Given this list of marker genes JMJD1C, TMEM18, NDRG2, RHBDF1, ASIC1, IDE, FLNB, PLEKHM3, GCSAM, SLC12A2, CD68, NEIL1, DRAM2, BID, MALAT1, PLBD1, PLA1A, BASP1, PLEC, SEMA7A, AHCYL2, GAN, PACSIN1, TLCD2, KSR1, TRRAP, RTN4RL1, NDST1, TMEM131, PTPN1, ZMAT3, TBC1D5, SLC41A2, SEPTIN9, ZNF362, RAP1GAP2, ANXA2, PRKAR2A, NCAPD3, TENT5A, WEE1, BCL9L, ZBTB20, CHD7, GIMAP4, MARVELD1, HERC2, TNRC6B, REV3L, SLC25A19 (solute carrier family 25 member 19), NFATC2, GIMAP7, LMNA, LEFTY1, CD86, HERC1, HMGN3, PKP1, CCDC122, GPR34, CDON, ACKR2, POU5F2, AHNAK, PLXNB2, SEMA4F, SP110, DIXDC1, MYCBP2, SBF2, SLC29A4, IL6R, CD81, IKZF3, MPEG1, MBD1, PAWR, SYNE1, PIK3R6, MAL, MFHAS1, B4GALT5, LIX1L, LRRK1, CD300LF, CDCA2, ITM2C, FAS, SLPI, OSBPL3, HELZ2, ME3, RABGAP1L, LYPLAL1, ABCA3 (NCBI Gene Id 21), PLCD3, CDH17, KCNK6 (potassium two pore domain channel subfamily K member 6), TK1, TJP2 (NCBI Gene Id 9414), NEK6, DENND11, TAF1D, ZNF217, ITPR2, ANKRD33B, WDFY4, LYST, CD80, ITGA4, RASSF4 (NCBI Gene Id 83937), CD44, BMPR1A, CMA1, IGHM, IGHG1, FMNL3, EVI2A, NID1, SSPN, ZFYVE1, CHRDL1, REEP3, ABCA5, CKAP4, SMG1, HNRNPH3 (heterogeneous nuclear ribonucleoprotein H3), FSCN1, SMYD2, ITGAE, CEP350, ARHGAP8, MORN1, EHD3, VPS13A, STT3B, PITPNC1 (phosphatidylinositol transfer protein cytoplasmic 1), TRABD2B, SYT11, CBFA2T3, ATP8B2, GRK5, TBC1D1, MYO1F, DDI2 (NCBI Gene Id 84301), CCDC88B, AICDA, THYN1 (NCBI Gene Id 29087), NT5E, LIPC (NCBI Gene Id 3990), PRSS16, VAT1, KCNN4 (NCBI Gene Id 3783), ID2, TMED8, ZDHHC2 (zinc finger DHHC-type palmitoyltransferase 2), EID2, CD180, ATXN1, PISD, SRMS, LMO7, KCNMB4, GNS, BAG2, MKI67, TRAF1, CXCR3, FFAR2 (free fatty acid receptor 2), ST8SIA6, MUC20, SPN, VOPP1, KLF12, LOXL3, CWC22, ADM, PARM1, P2RY13, S1PR3, CLIC4, SH3PXD2A, KCTD14, PLXNC1, PLD2, HAVCR1, STAU2, GPR137B, MAP2K6, TMEM38B, MGAT4B, PVT1, MICALL1, DYRK3, RITA1, HELZ, NBEAL2, ARHGEF12, CLN6, here is a description of the gene set: Genes down-regulated in T reg: XBP1 knockout versus wildtype. from publication Fu W, Ergun A, Lu T, Hill JA, Haxhinasto S, Fassett MS, Gazit R, Adoro S, Glimcher L, Chan S, Kastner P, Rossi D, Collins JJ, Mathis D, Benoist C (PMID 22961053) The transcription factor FoxP3 partakes dominantly in the specification and function of FoxP3+ CD4+ T regulatory cells (Tregs), but is neither strictly necessary nor sufficient to determine the characteristic Treg transcriptional signature. Computational network inference and experimental testing assessed the contribution of several other transcription factors (TFs). Enforced expression of Helios or Xbp1 elicited specific signatures, but Eos, Irf4, Satb1, Lef1 and Gata1 elicited exactly the same outcome, synergizing with FoxP3 to activate most of the Treg signature, including key TFs, and enhancing FoxP3 occupancy at its genomic targets. Conversely, the Treg signature was robust to inactivation of any single cofactor. A redundant genetic switch thus locks-in the Treg phenotype, a model which accounts for several aspects of Treg physiology, differentiation and stability. Human Gene Set: GSE40273_XBP1_KO_VS_WT_TREG_DN species: Homo sapiens